The following is a description of a gene set: from publication Liberzon A, Birger C, Thorvaldsdóttir H, Ghandi M, Mesirov JP, Tamayo P (PMID 26771021) species: Homo sapiens Human Gene Set: HALLMARK_SPERMATOGENESIS Genes up-regulated during production of male gametes (sperm), as in spermatogenesis., and this is the list of marker genes: CCNB2, TNNI3, TEKT2, IP6K1, AURKA, TKTL1, IFT88, SCG3, CLVS1, RPL39L, CLPB, SLC12A2, KIF2C, TTK, GSG1, MAST2, DMRT1, CSNK2A2, HBZ, DBF4, STRBP, ACTL7B, ADCYAP1, SCG5, POMC (proopiomelanocortin), DDX4, ZNRF4, GRM8, RFC4, MTNR1A, VDAC3, CRISP2, HSPA4L, PDHA2, TSN, ACRBP, IL12RB2, IL13RA2, ODF1, GAD1, SLC2A5, STAM2, PAPOLB, SNAP91, RAD17, TNP1, MEP1B, TULP2, AKAP4, ART3, DNAJB8, OAZ3, ACE, GAPDHS, NPY5R, ACRV1, IDE (insulin degrading enzyme), ZPBP, H1-6, GMCL1, NF2, CDK1, TSSK2, CDKN3, ADAD1, NEFH, COIL, BUB1, BRAF, TALDO1 (NCBI Gene Id 6888), MAP7, PRKAR2A, PCSK4, TNP2, MLF1, SPATA6, DPEP3, HOXB1, LPIN1, GPR182, CCNA1, CFTR, PGK2, JAM3, EZH2, ZC3H14, NPHP1, YBX2, PGS1, ADAM2, PHKG2, HSPA2, DCC, GSTM3, CHRM4, PRM2, PSMG1, SHE, SEPTIN4, NEK2, ZC2HC1C, GFI1, CST8, MLLT10, NAA11, PHF7, CCT6B, NOS1, AGFG1, ALOX15, PEBP1, DMC1, DDX25, ARL4A, TCP11, SIRT1, CHFR, TUBA3C, PCSK1N, LDHC, HSPA1L, ELOVL3, PIAS2, PACRG, CAMK4, CNIH2, TLE4, PARP2, NCAPH, SYCP1, SPMAP2, MTOR, CLGN, TOPBP1, HTR5A